Given this list of marker genes LRWD1 (NCBI Gene Id 222229), SERAC1, PAM, CD200, POLR1G, TSEN2, GON7, UBE2NL, FASLG, DNAAF10, ALG6, TNFRSF9, FADD, GABRB1, ILDR2, LIF, TIMM8A, FBXL18, SLC39A14, SERPINB2 (NCBI Gene Id 5055), MECR, PPIL1, DLAT, STXBP6, BDH1, RAB11FIP1, CD8A, MED18, EGR3, VMP1, C1GALT1C1, CRNKL1, POLR3D, SLC7A1, ZNF234, PTPN14 (NCBI Gene Id 5784), OR7E36P, GCLM, TTC9C, RAPH1, IFIT3, TRPV1, HCP5, KEAP1, ERLIN1, TCTN3, HIVEP3 (NCBI Gene Id 86368), CHAC2, PRPF38A, EIF4EBP1, TTLL12, CTTN, RBBP8, ARHGAP18, LINC01134, RAB27B, PSMG1, FAHD1, MRPL35, SRM, ALG1, BAZ1B, PER2, MMACHC, PA2G4, SDC4, PTCHD1, SCFD2, PACSIN3, P3H1, DUSP14, CD84, SLC19A1, SLC52A2, JMJD4, LYAR, GPN3, RTP4, ELAVL1, CLN6, PRMT1, PHLDA1, SORD, LAMP3, PFAS, SMKR1, LYSET, ZPR1, ZNF709, MED20, NETO2, PCBP3, MLEC, ZNF232, TNFRSF4, GLMN, METTL2B, JMJD8 (jumonji domain containing 8), BCAT1, SH2D2A, PHF23, POP1, ELP5, COA7, TNF, YARS2, ZC3H10, GEMIN6, TREML2, ACTL6A, AK2, PIGM, LEKR1, POLR1A, CRIM1, DIPK1A, MYB (NCBI Gene Id 4602), ECE2, CD38, FBLN7, CDK4, GFOD1, TXLNA, TFPI2, NFKBID, HOMER1, TBX21, COLGALT1, RRS1, PAGR1, HPDL, HNRNPUL2, GNG8, NAB2, ASPHD2, ARMC6, MOB3C, LARP4B, CHN2, XCL1, INO80B (NCBI Gene Id 83444), PARP14, MOCS2-DT, RIF1, IL2RA, CCDC86, RBM28, MRPL15, CBR1, KCNK5, RBM14, PRADC1, CDC45, GMPPB, PEAK1, MRS2 (NCBI Gene Id 63855), IL1R1, PDCD2L, TSPAN31, MFSD6, CISH, FNTB, MED21, NFE2L3, CEP15, IL1RN, MECOM, CAAP1, EGR2, RAB39B, COA3, IRF4, FBXO22 (F-box protein 22), STX6, PDP2, ZNF879, TMEM223, RRP9, ZNF239, BTLA, ATXN1, POU2AF1, MATK, DPAGT1, AEBP1, TEX30, CLDN1, FRMD4B, IL3, SPRY4, ENDOG, DLC1, ZNF485, RCC1, HSF5, UCK2, here is a description of the gene set: Human Gene Set: GSE17974_CTRL_VS_ACT_IL4_AND_ANTI_IL12_6H_CD4_TCELL_DN from publication Elo LL, Järvenpää H, Tuomela S, Raghav S, Ahlfors H, Laurila K, Gupta B, Lund RJ, Tahvanainen J, Hawkins RD, Oresic M, Lähdesmäki H, Rasool O, Rao KV, Aittokallio T, Lahesmaa R (PMID 20620947) The aim of this dataset was to study in detail the transcription kinetics initiated by cytokine IL-4 in early differentiation of Th2 cells. Genes down-regulated in comparison of untreated CD4 T cells at 0 h versus the cells treated with IL4 and anti-IL12 at 6 h. species: Homo sapiens